The following is a description of a gene set: from publication Yevshin I, Sharipov R, Kolmykov S, Kondrakhin Y, Kolpakov F (PMID 30445619) species: Homo sapiens Genes containing one or more binding sites for (SRPK2) in their promoter regions (TSS -1000,+100 bp) as identified by GTRD version 20.06 ChIP-seq harmonization. Human Gene Set: SRPK2_TARGET_GENES, and this is the list of marker genes: C6orf47, HR, VCP, FMN2, EZH1, FARP2, DCC, ADAMTS9, LINC02142, TBC1D27P, LINC01877, GIT2, SPTLC3, CIBAR1, MAP4K1, DRAM2, MAB21L2, SYTL2, CISD2, ZNF840P, SOS1, IGHVII-40-1, SLTM, KRBA1, ACSS2, TCP11L2 (t-complex 11 like 2), POLR1HASP, RN7SL375P, SPMIP4, PTGER4, KLRF2, BCAT1, MYOZ2, OR2L3, LINC00640, ENSG00000260660, RNU6-274P, THOC2, CLEC2D, SYNJ2-IT1, LINC01613, LINC02114, DLG1, HSPG2 (NCBI Gene Id 7796), LINC01478, EIF4HP1, RNU1-8P, RAB2A, LINC01653, GTF2H4, PGBD4P8, FAM184B, MROH7, GDA, RORA, CDCA7L, LYPLAL1-AS1, ATP6V1C2, SPTBN2, HTR3E-AS1, LRBA, LRRC43, MMAA, THOC5, UBE2D3, BTBD8, LINC00877, LILRB1-AS1, ANKRD30BL, LINC02052, LINC02740, NMT2, FMO6P, SLC22A11, LNCRI, MYADM-AS2, TARS3, DYRK4, HOXC6, CYCSP41, PFKP, VARS2